Given this list of marker genes APOB, P4HB, MTTP, CETP, LPA, APOF, here is a description of the gene set: LDL remodeling Human Gene Set: REACTOME_LDL_REMODELING studied in species Homo sapiens